The following is a description of a gene set: Mouse Gene Set: REACTOME_BASE_EXCISION_REPAIR_AP_SITE_FORMATION Base-Excision Repair, AP Site Formation species: Mus musculus, and this is the list of marker genes: H2bc4, H2bc23, H4c6, H2ax, Mbd4, H2bc12, H4c16, H2ac11, H4c8, H4c2, Mpg, Neil2, H2ac15, H2ac19, H2ac23, H4c3, H4c17, H2bc3, H2ac24, Mutyh, H2ac6 (H2A clustered histone 6), H2bc14, H2ac22, H2ac4, Acd, H4c14, H2bc22, H4c11, H2bc8, Ung, H2bc13, Nthl1, Terf1, H3f4, Smug1, H4c12, H2ac18, H2ac8, Terf2, H2ac12, H4c9, H2bc6, H2bc21, H2bc15, H2bc26, Neil3, H2aj, Pot1a, H2ab2, H2ac10, H2bc1, H4c18, H4c4, H2bc9, Terf2ip, H2ab3, H2ac20, H4c1, H2az2, H2bc7, H2ac7, Tdg, Ogg1, H2ac13, H2ab1, Neil1, H2bc24, H2bc11